The following is a description of a gene set: Constitutive ablation of the Yin Yang 1 (YY1) transcription factor in mice results in peri-implantation lethality. In this study, we used homologous recombination to generate knockout mice carrying yy1 alleles expressing various amounts of YY1. Phenotypic analysis of yy1 mutant embryos expressing approximately 75%, approximately 50%, and approximately 25% of the normal complement of YY1 identified a dosage-dependent requirement for YY1 during late embryogenesis. Indeed, reduction of YY1 levels impairs embryonic growth and viability in a dose-dependent manner. Analysis of the corresponding mouse embryonic fibroblast cells also revealed a tight correlation between YY1 dosage and cell proliferation, with a complete ablation of YY1 inducing cytokinesis failure and cell cycle arrest. Consistently, RNA interference-mediated inhibition of YY1 in HeLa cells prevents cytokinesis, causes proliferative arrest, and increases cellular sensitivity to various apoptotic agents. Genome-wide expression profiling identified a plethora of YY1 target genes that have been implicated in cell growth, proliferation, cytokinesis, apoptosis, development, and differentiation, suggesting that YY1 coordinates multiple essential biological processes through a complex transcriptional network. These data not only shed new light on the molecular basis for YY1 developmental roles and cellular functions, but also provide insight into the general mechanisms controlling eukaryotic cell proliferation, apoptosis, and differentiation. species: Mus musculus from publication Affar el B, Gay F, Shi Y, Liu H, Huarte M, Wu S, Collins T, Li E, Shi Y (PMID 16611997) Genes up-regulated in MEF cells (embryonic fibroblast) expressing ~25% of YY1. Mouse Gene Set: AFFAR_YY1_TARGETS_UP, and this is the list of marker genes: Cpeb1, Krt19, Klk8, Pdlim3, Btg2, Pltp, Fabp3, Xlr3a, Tnnc1, Blcap (NCBI Gene Id 98987), Snurf, Usp20, Zfp40, Bak1, Nptx2, Elovl2, Abat, Gria3, Tnnc2, Irag1, Ctnnd2, Mal, Hhip, Wnt16, Slc1a6, Pbx4, Acox1, Bex1, Arf2, Tcfl5, Zfp385a, Wt1, Ldhb, Flt1, Selenom, Tpd52l1, Stx3, Kif5b, Plcb4, Id4, Egfr, Cdo1, Ms4a1, Polk, Dstyk, Rnf41, Pex19, Lrp2, Efemp1, Il17d, Gbp4, Bcl2l1, Hsf2, Tgm2, Celf4, Adam15, Ndufa7, Zfp113, Syt11, Map6, Hacl1, Epha7, Nherf2, Ppp1r15a, Lgals9, Itgb6, Bmp4, Abca3, Epha2, Hemgn, Bmp6, Myl1, Myom1, Fjx1 (NCBI Gene Id 14221), Sim1, Selenop, Snrpn, Pfkfb2, Tpm1, Rnd3, Ebf2, Cryab, Txnip, B4galt4 (UDP-Gal:betaGlcNAc beta 1,4-galactosyltransferase, polypeptide 4), Actc1, Gpc3, Kdr (NCBI Gene Id 269657), Pafah2, Cfh (NCBI Gene Id 192290), Ldb3, Chodl, Cdkn1c, Tnfrsf10b, Pmm1, Fos, Arr3, Sh2d1a, St6galnac3 (ST6 (alpha-N-acetyl-neuraminyl-2,3-beta-galactosyl-1,3)-N-acetylgalactosaminide alpha-2,6-sialyltransferase 3), Kif17, Spock3, Rbmx, Plod2, Klrb1b, H13, H2ac18, Mycn, Slc12a5, Ehd1, Ajuba, Tinagl1, Tap1, BC001981, Cbln1, Casp7 (NCBI Gene Id 12369), Myo1c, Plcz1, Uncx, Cftr, Lamb2, Myh2, Slc2a4, Abcc5, Sin3a, Dusp1, Psrc1, Spag1, Stk25, H1f2, Nrg3, Tbx2, Dleu2, Uchl1, Hsd17b1, Masp1, Rorc, Fyb1, Cdkn1a, Neurod6 (neurogenic differentiation 6), Gbp2, Sfn, Prox1, Sox2, Tgfb2, Nap1l3, Gm4836, Ubc, Gfer, Serpinb3a, Ramp2, Pmaip1, Drd4, Atp6v0e2, Bdnf, Slc27a3, Gpr137b, Myh1, Dmpk, Myh3, Tnni1, Myh7, Ankrd1, Ntf3, Slc2a3, Mmp2, Sulf2, Nnat, Mpg, Gadd45g (NCBI Gene Id 97898), Prss35, S1pr5, Ehf (NCBI Gene Id 99194), Clu, Tph1, Psg19, Zfp264, Col10a1, Rpgrip1, Abcd4, Col19a1, Cend1 (cell cycle exit and neuronal differentiation 1), Ngfr, Fas, Ttll1, Dcxr, Tslp, Tssk2, Src, Mdm2, Surf1, H2bc4, Trp53inp1, Ctsf, Icam1, Ptp4a3, Ackr3, Mylpf, Anxa8, Alcam, Fxyd6, Abca1, Slc6a14, Pawr, Jak3, Itga9, Perp, Lpin1